Given this list of marker genes MIX23, PNPO, CDCA5, ADAM23, PDE1B, ITGA2, EDN2, ADGRE5, POLR3D, NAB2, CTNNA2, AFG2A, ABCC1, HCK, REG3G, KCTD10, SLC25A10, OCEL1, AKAP8, MMP15, SNRPB2, VRK3, VNN1, C3AR1, PML, RHOB, AIF1, ACKR4, RPRM, URI1, SNTB1, CCS, UBA7, GRSF1, SEMA3A, GAL, HLA-DOB, RPS14, PPP2R5C (protein phosphatase 2 regulatory subunit B'gamma), GABARAPL1, MSLN, MCUR1, METAP2, STK24 (serine/threonine kinase 24), MAGED2, FAM89B, ASB6, FNTB, RNF114, SNRNP27, PSMG1, KAT7, USP42, CLEC4F, IFT27, HIVEP3, TSSK2, PPP2R5A, PSMD3, MMP11, KL, PAFAH1B2, FOXC1, ADRB2, GPX1, PPIC, COL4A3, ACYP2, SEC11C, SOX1, CHRNG, GTSE1, ING4, HIPK1, MTOR, TIAL1, GSG1, PAX1, TESK1, HOXC8, FUT8, KCNA3, RASD1, PREB (prolactin regulatory element binding), TBC1D1, RPS6KA3, PFKFB1, PTPRJ, BAAT, ST6GALNAC1, RASL11B, ICA1, IQGAP3, AGTRAP, PKP1 (plakophilin 1), CD7, BPNT1, HAND1, HNRNPAB, ZBTB14 (zinc finger and BTB domain containing 14), AMBRA1, CXCL3, TAL2, DNMT3A (DNA methyltransferase 3 alpha), ENOPH1, C19orf73, FGFR1OP2, TWIST2, UBE2T, RDH5, WRNIP1 (WRN helicase interacting protein 1), HSPA1A, KCNMA1, CDC42EP4, TM4SF1, HBS1L, PLA2G4A, GOT1, LGALS9B, CNGA2, TM4SF5, TGFB3, ARL6IP4, MRPL54, FBXL3, POLR1B, SRP19, TNFRSF18, ZBED3, GALT, TNIP1, CPSF7, ENDOG, ERGIC1, LRPAP1, CLEC4E, MRPS33, CSF2, TNF, CDK2, PXN, DLX6, ZNF639, TXNIP (NCBI Gene Id 10628), RBL1, TSG101, ANAPC1, FLOT2 (flotillin 2), DNAJA1 (DnaJ heat shock protein family (Hsp40) member A1), PDS5B, RAD54L, FEZF2 (NCBI Gene Id 94016), LHX6, MAP3K2, FMNL3, PARN, VASP, C15orf39 (chromosome 15 open reading frame 39), ANG, GRIN2D, PRPS2, IL1A, WASF2, NECAP1, CPSF2, FABP6, CXCL2, XCL1, MOS, MAP4K1, ONECUT1, PEX13, AGER, PRRC1, MAPRE3, LAMC2, ITPK1, MID1, CAPN6, GDF15, IFRD1, STX18, ERN2, BMPR1A, ARNT2, A2M, SCN8A (sodium voltage-gated channel alpha subunit 8), SUB1, TCIRG1, GPC4 (NCBI Gene Id 2239), ARX, GYS1 (NCBI Gene Id 2997), VAC14, SAP30 (Sin3A associated protein 30), RFC1, AKIRIN2, GHRH, C8G, KCNK4, IER2, here is a description of the gene set: species: Homo sapiens from publication Yosef N, Shalek AK, Gaublomme JT, Jin H, Lee Y, Awasthi A, Wu C, Karwacz K, Xiao S, Jorgolli M, Gennert D, Satija R, Shakya A, Lu DY, Trombetta JJ, Pillai MR, Ratcliffe PJ, Coleman ML, Bix M, Tantin D, Park H, Kuchroo VK, Regev A (PMID 23467089) Despite their enormous importance, the molecular circuits that control the differentiation of Th17 cells remain largely unknown. Recent studies have reconstructed regulatory networks in mammalian cells, but have focused on short-term responses and relied on perturbation approaches that cannot be applied to primary T cells. Here, we develop a systematic strategy – combining transcriptional profiling at high temporal resolution, novel computational algorithms, and innovative nanowire-based tools for performing gene perturbations in primary T cells – to derive and experimentally validate a temporal model of the dynamic regulatory network that controls Th17 differentiation. The network is arranged into two self-reinforcing and mutually antagonistic modules that either suppress or promote Th17 differentiation. The two modules contain 12 novel regulators with no previous implication in Th17 differentiation, which may be essential to maintain the appropriate balance of Th17 and other CD4+ T cell subsets. Overall, our study identifies and validates 39 regulatory factors that are embedded within a comprehensive temporal network and identifies novel drug targets and organizational principles for the differentiation of Th17 cells. Genes up-regulated in CD4 T helper cells (60h): Th0 versus TGFB1 and IL6. Human Gene Set: GSE43955_TH0_VS_TGFB_IL6_TH17_ACT_CD4_TCELL_60H_UP